Given this list of marker genes Ophn1, Foxf1, Lama1, Pard3, Arf6, Gja1, Ptk7, Myo9a, Cdc42, Wnt5a, Rhoa, Fat1, Syne4, Cyth3, Crb3, Hes5, Hes1, Frmd4a, Tcf15, Fbf1, Ift20, Shh, Vangl2, Camsap3, Hey1, Sh3bp1, Myo18a, Sipa1l3, Frmd4b, Cyth1, Ttc8, Spag6l, Msn, Nherf1, Golph3, Fermt1, here is a description of the gene set: The specification and formation of anisotropic intracellular organization of an epithelial cell. Mouse Gene Set: GOBP_ESTABLISHMENT_OF_EPITHELIAL_CELL_POLARITY species: Mus musculus